Given this list of marker genes SLC16A3, ACACB (acetyl-CoA carboxylase beta), SLC16A7, EMB, SLC16A1, here is a description of the gene set: studied in species Homo sapiens Human Gene Set: GOBP_PLASMA_MEMBRANE_LACTATE_TRANSPORT The directed movement of lactate across a plasma membrane.